The following is a description of a gene set: Human Gene Set: HP_PES_PLANUS Pes planus A foot where the longitudinal arch of the foot is in contact with the ground or floor when the individual is standing; or, in a patient lying supine, a foot where the arch is in contact with the surface of a flat board pressed against the sole of the foot by the examiner with a pressure similar to that expected from weight bearing; or, the height of the arch is reduced. species: Homo sapiens, and this is the list of marker genes: TGFB3, PRR12, FGF17, ATCAY, TTN, AHCY, SPEN, PROK2, MED12L (mediator complex subunit 12L), COL12A1, B3GALT6, MED12, AGA, FGF8, RYR1 (NCBI Gene Id 906), FGF13, UCHL1, HK1 (NCBI Gene Id 59333), COL1A2, FBXO11, HESX1, COPB1, HEATR3, KMT2A, PRKG2, DYM, CHD7, WDR11, PDE4D, RIN2, FLNB (NCBI Gene Id 8413), HDAC8, GTF2IRD1, MTR (NCBI Gene Id 4548), TGFBR1 (transforming growth factor beta receptor 1), CANT1, TFE3, RFWD3, ATP6V1E1, PEX6, FOXG1, LMX1B, SLC16A2, SCARF2, SIL1, LIMK1, SLC39A13 (NCBI Gene Id 91252), SOX10, SPIN4, EBF3, TRAF7, FEZF1, STX1A, RAB3GAP2, GFPT1, SLX4, CLCN4, SMARCA2, ALDH18A1, CNOT3, GATA4, SPRTN, CUL7, AMMECR1, EGR2, SLC10A7, CDK10, CEP152, MGAT2, WBP4, IARS2, CFL2, PRDM5, VLDLR, FANCI, AHDC1, TAOK1, DPAGT1, LOX, GRIN2D, DNAJC30, ANOS1, COL9A3, EMILIN1, BRF1, FLII, PCDH19, PROKR2, GRIA3, SLC1A3, SPRED2, PACS1, DHX30, HCN1 (NCBI Gene Id 609), CRKL, TRIO, RSPRY1, SOX9, GABRD, RTN2, JARID2, CSGALNACT1, TACR3, XYLT1, SH3TC2, FLNA, SALL4, EIF4H, RAI1 (retinoic acid induced 1), DMD, MYLK, TCF4, LMNA, UBAP2L, H4C11, ASXL3, HNRNPK, FGFR1, CDC42BPB, TGFB2, ERI1, TBL1XR1, CUL4B, FANCD2, GJA8, TONSL, NDST1, RAB7A, BSCL2, COL5A2, GDF11, FANCE, DUSP6, AP1G1, NAA20, SBF2, THSD4, ALMS1, DPM3, GNB1, CHD8, ATP7A, KAT6A, RNU4-2, PMP22, CREBBP, BRIP1, PHF8, TRPS1, SCN9A, VPS37D, ASCC3, DPH1, PYCR1, PMPCA, KCNH1, TPM3, XRCC2, PLOD1, NONO, ATP6V0A2, AP4E1, NPR3, SCN2A, SLC5A7, SCN1B, BAZ1B, CLIP2, ATP1A2, KANSL1, GTF2I, MAB21L2, SYT2, ARX, MYH7, UBE2A, COL5A1, BICD2, RLIM, ATP6AP2, WAC, DLG4, EIF3F, ELN, HNRNPH2, NSD1, SMC5, FANCM, USP9X, DACT1, CTSC, PIGG, PRRT2, PYROXD1, SPTAN1 (spectrin alpha, non-erythrocytic 1), MMP2, FLRT3, SLC26A2, ADNP, GAN, U2AF2, PRX, TBX4, RPS6KA3, DCC, EXT2, ALG2, KCNN3, FBN1, GJA5, FLI1, ABL1, LAS1L, GABRG2, SEMA3A, GMPPB, TMEM270, RAD51, ATP1A3, FANCB, PMM2, BCR, HERC1, EFEMP1 (NCBI Gene Id 399564), CCNK, MYPN, FANCG, SMAD3, CHCHD10, BRCA2, UBE2T (ubiquitin conjugating enzyme E2 T), FMR1, COL9A1, CBFB, METTL23, MYH11, SLC9A7, IL17RD, CIC, CTCF, ZDHHC9 (NCBI Gene Id 93950), MPV17, GTF2IRD2, AP4S1, TET3, FANCF, CRLF1, SOX5, STAG2, DPH2, HS6ST1, PUF60, PALB2, TRMT1, EXOC6B, SMAD4 (SMAD family member 4), BGN, ATRX, PPIB, B4GALT7, NDNF, CHST3, H3-3B, WASF1 (NCBI Gene Id 8936), NCF1, SALL1, HSPG2, AP4M1, APC2, SMAD2, STX1B, GRIN2B, CACNA1A, GNPTG (N-acetylglucosamine-1-phosphate transferase subunit gamma), PIEZO2, TGFB1, ZEB2, GDF6, FBLN5, PRKG1, SLC29A3, ZNF469, AEBP1, MAD2L2 (NCBI Gene Id 10459), IQSEC2, H4C5, TRPM3, MFAP5, CCDC141, MAT2A, ATP6V1B2, DPH5, RFC2, BRWD3, EHMT1, TPM2, TRPV4, ERCC4, ATR, METTL27, AFF3, EP300 (E1A binding protein p300), SELENON, EIF5A, ZNF148, B3GAT3, ADGRV1, ALG14, COL1A1, CWC27, GARS1, FOXE3, COL2A1, VPS13B, MAPK1, TPR, SLC37A4, ACTA2, FIBP, FKBP6, FANCL, TMCO1, TBC1D23, SNRPN, NDUFAF6, MPZ, FANCC, FKBP14, SPRY4, TAF4, FGD1, XYLT2, CADM3, COL27A1, NDRG1, COMP, GORAB, FANCA, DEAF1, TGFBR2, BPTF (bromodomain PHD finger transcription factor), L1CAM, SCN1A (NCBI Gene Id 6323), MORC2, GDF5, SCAF4, IPO8, KDELR2, MTOR, RAD51C, MAPRE2, SCO2, CACNA1C, HIVEP2, GABRA1, HEY2, TDO2, BRCA1, ASPH, SARS1, TBL2, IFITM5, BUD23, SEC23A, C12orf57, SKI, TLK2, AP4B1, SBF1, CLDN11, RAB33B